Given this list of marker genes SLC35D1, DMP1, MMP9, TBX5, NAA60, IARS2, PRKACB, COL2A1, RTL1, TMEM270, PCNT, CCDC134, TMEM237, FBN1, EIF2AK3, KAT6A, HEATR3, HERC2, OCRL, SHOX, SETBP1, MAP3K7, TCTN3, WNT7A, MEGF8, IDS, PTH1R, CEP290, RFC2, FIG4, CPLANE1, RPL13, CYP19A1, BGN, ACTA1, B3GAT3, PDGFRB, SLC10A7, RSPRY1, NFIX, MAPK1, EHHADH, HSPG2, CAMK2A (NCBI Gene Id 815), IL6ST, PRKAR1A, IFT122, BMPR1B, MPZ, HPGD, RPGRIP1, SLC34A1, LMOD3, KLHL41, IFT57, DYNC2I1, KDELR2, BMP4, AIP, CTNS, PWAR1, EXT2, EVC, RSPO2, COL9A2, NEB, ZNF699, SH3PXD2B, MAN2B1, CSF1R, RPS6KA3, GPR101, ORC1, VPS35L, SLC2A2, ARSK, GALNS, FGF23, NDUFAF6, LONP1, HS6ST1, DYM, CYP3A4, CCDC47, SFRP4, TBC1D7, CC2D2A, SATB2, TMEM38B, CLCN5, TTI1 (TELO2 interacting protein 1), CLIP2, POLR3A, TMEM53, EVC2, STX16, RAD21, ORC6 (origin recognition complex subunit 6), PCYT1A, LTBP1, TNFRSF11B, CTCF, SF3B2, EFL1, IFIH1, EFEMP2, CRTAP, BMP1, ANO5, H3-3B, PWRN1, BAZ1B, CBFB, COMP, VPS13B, IFT52, TBL2, EXT1, SLC34A3, RAB23, SLCO2A1, TMEM165, CENPT, COL10A1, GTF2IRD2, VPS37D, CFL2, MMP13, MEG3, ZEB2, TRPV6, TFE3, GLI1, MKS1, LRP5, FAM111A, KRAS, TMEM231, RNU4ATAC, P4HB, ARSB (arylsulfatase B), TRIP11 (thyroid hormone receptor interactor 11), COL1A1, LIFR, COG5, HOXA11, SPTBN1, PAPSS2, MTAP, NSD1, SNX10, LIMK1, WDR62, CA2, GNPNAT1, DLK1, GNPTG, ERI1, INPPL1, DNAJC30, MAP2K2, MAPK8IP3, RECQL4, GAN, XYLT1, TCTN2, IFT43, TRPS1, SEC24D, ACP5, GUSB, B3GALT6, NOTCH2, DDRGK1, POR, PMP22, NPR2, GLI3, NCF1, FKBP10, IPO8 (NCBI Gene Id 10526), SOX9, WDR35, BHLHA9, ALPL, TCTN1 (NCBI Gene Id 79600), ARCN1, CSPP1, B2M, ACAN, ANTXR2, KANSL1, NPAP1, GDF5, ROR2, CYP2R1, KIF7, GTF2IRD1, IDH2, TGFB1, POLRMT, MAP2K1, PTPN11, UGP2, IFT172, SCARF2, CHST3, GORAB, SGMS2, PLAAT3, CTC1, RPGRIP1L, ATP7A, B9D1, HNRNPH1, PTDSS1, MTX2, BCOR, CDC45, SNORD116-1, FAM20C, SERPINH1, CLTCL1, FBN2, NEK8, ATP6V0A2, SPARC, CCN6, LAMA5, NKX3-2, IHH, SNORD115-1, TPM2, NEPRO, RMRP, MATN3, TNFRSF11A, ANAPC1, FGFR2, RBM8A, RIPK4, RAB33B, SLC26A2, FGFR3, EIF4H (NCBI Gene Id 94573), TCIRG1 (T cell immune regulator 1, ATPase H+ transporting V0 subunit a3), BRAF, MAGEL2, CLDN16, B4GALT7, ZPR1, CREB3L1, TMEM216, CANT1, WDR19, IDH1, SKI, UFSP2, COL11A2, MKRN3, PHLDB1, KIAA0753, BUD23, TENT5A, ESCO2, GTF2I, GLB1, PRKACA, COL9A3, DYNC2H1, TNFSF11, TMEM107, FLNB, FN1, SERPINF1, ENPP1, P3H1, ATRX, COL11A1, TUBB3, CSGALNACT1, BPNT2, B9D2, PEPD, TXNDC15, CBS, TONSL, CRKL, TGDS, CYP27B1, DDR2, FLNA, TMEM67, LRP4, METTL27, MBTPS2, NF1, KIF22, POLR1A, LBR, COL1A2, SMOC1, FKBP6, PRKG2, SP7 (NCBI Gene Id 121340), P4HTM, PYCR1, BRF1, DYNC2LI1, GNAS, HS2ST1, HBB, MCTP2, NEK9, RUNX2, PHEX, FIBP, ZBTB20, BCR, TBXAS1, CILK1, CCN2, SPART, VAC14, CLCN7, VDR, PLOD2, GJA1, PDE4D, TBCE, PUS3, STX1A, FGFR1, ADNP, PPIB, TRPV4, COL9A1, ELN, SPRED1, SOST, IDUA, here is a description of the gene set: studied in species Homo sapiens Abnormal diaphysis morphology An abnormality of the structure or form of the diaphysis, i.e., of the main or mid-section (shaft) of a long bone. Human Gene Set: HP_ABNORMAL_DIAPHYSIS_MORPHOLOGY